The following is a description of a gene set: from publication Chen Y, Wang X (PMID 31504780) Mouse Gene Set: MIR_34A_5P Genes predicted to be targets of miRBase v22 microRNA mmu_miR_34a_5p in miRDB v6.0 with MirTarget v4 prediction scores > 80 (high confidence targets). studied in species Mus musculus, and this is the list of marker genes: Met, Trank1, Gpr22, Unc13c, Car7, Notch2, Mdm4, Ccdc85a, Fut8, Rragc, Strn3, Cdc25a, Numbl, Brinp1, Rab21, Vwa5b2, Atp2b4, Atg4b, Snx12, Rfx3, Arhgap1 (NCBI Gene Id 96949), Hexa, Patz1, Coro1c, Tmem164, Scamp4, Smim15, Ubl4a, Lyplal1, Foxj2, Casp2, Add2, Ergic1, Speer4a1, Bnc2, Ubp1, Vdr, Snai1, Asb1, Acsl4, Ago4, Srpra, Eml5, Tmem255a, Slc25a53, Gpr165, Tmed8, Pdgfrb, Pxdc1, Htr2c, Brpf3, Fam76a, Kcng2, Lzts3, Thtpa, Klf4, Krtap16-1, Lman1, Rmnd5a, Ppp2r5a, Pacc1, Nav1, Cbfa2t3, Celf3, Azin2, Camta1, Sgta, Svop, Rab43, Mllt3, Cplx2 (complexin 2), Rhbdl3, Btn1a1, Ttc19, Fam83h, Rhoh, Arhgap26, Scml2, Galnt7, Ei24, Ppm1b, Dcx, Cntn2, Kcna6, Cuedc1, Hspb6, Calcr, Kti12, 9930012K11Rik, Mmp25, Dixdc1, Zmym4, Arap1, Sidt2, Mex3c, Il6ra, Nectin1, Itch, Mta2, Osgin2, Kitl, Pitpnc1, Ppfia1, Lgr4, Dgkb, Dgkz, Nat8l, Csf1r, Golph3l, Zfp282, Car10, Gm14326, Tmem45a2, Gmfb, Tom1, Frk, E2f5, Abr, Mtcl2, Ldha, Ppp2r3a, Aff4, Zdhhc16, Vcl (NCBI Gene Id 268722), Plcb1, Rras (related RAS viral (r-ras) oncogene), Akap6, Slc35g2, Zfp644, Rhoj, Pkp4, Syt1, Abcd1, Abtb3, Daam1, Slc4a7, Notch1, Synj1, Dcaf7, Arid4b, Rimoc1, Gm14391, Taf5, Tnrc6b, Ldb3, Calcb, Tgif2, Pnoc, Fam107a, Creb3l2, Tmem79, Lef1, Ccne2, Sema4c, Slc4a8, Pip5k1a, Tppp, Ppargc1b, Dpp8, Snx15, Fut9, Zfp775, Zfp281, Acsl1, Gdf2, Erp44, Jade2, Pacs1, Tbc1d2b, Erc1, Ing5 (inhibitor of growth family, member 5), Zfp512, Usp31, Etl4, Gabra3, Pogz, Mmab, Pdgfra (platelet derived growth factor receptor, alpha polypeptide), Thumpd1, Chd1, Ppp1r11, Nav3, Asic2, Tbl1xr1, Vat1, Rtl4, E2f3, Mycn, Ucn2, Pip4p2, Lhx2, Slc25a27, Slc44a2, Lman2l, Ltbp2 (NCBI Gene Id 16997), Foxn2, Clcn3, Tpd52, Usf1, Mpp2, 4930544G11Rik, Cacna2d2, Ddx17, Shkbp1, Sirt1, Bcl6, Polq, Metap1, Pea15a, Rtn4rl1, Rps6ka4, Gpr158, Zkscan16 (NCBI Gene Id 634619), Wscd2, Ankrd52 (ankyrin repeat domain 52), Tent5a, Serpinf2, Mgat5b, Ahcyl2 (NCBI Gene Id 74340), Slc6a1, Chmp7, Stag3, Hcn3, Map2k1, Ptms, Nrip3 (nuclear receptor interacting protein 3), Fbxo30, Scn2b, Zfp120, Satb2, Vamp2, Tanc2, Dpysl4, Gmnc, Mgat4a